Given this list of marker genes DNAJC16, RNF139, TSC1, UGT2B4, PROS1, EPB41L5, ACSF2, SYNCRIP, ASH2L, VCPKMT (valosin containing protein lysine methyltransferase), PRLR, NANOS2, RAB28, VCF1, NOD1, ZNF780B, CREBRF, THSD7B, AVL9, SLC17A7 (NCBI Gene Id 57030), LAMP3, CDC73, FAM229B, CCP110, AP3S1, EPHA4, MYCBP, MLF1, C2orf88, SLC35F5, NKAIN2, FAM118A, ATG16L1, LUC7L3, CDIN1, SYNC, BDNF, ATRN, MRPL3 (NCBI Gene Id 11222), RDH10, FOXJ3, ZNF736, PPP1R14C, ADAMTS15, UNC5D (unc-5 netrin receptor D), PIK3C2B, KIF5C, VPS13C, COX16, RAP2C, SYNJ2BP-COX16, ZXDB, B3GNT5 (UDP-GlcNAc:betaGal beta-1,3-N-acetylglucosaminyltransferase 5), SNX18, FOXN1, SMURF2, SPEN, STRN3, SLC22A4, SCAF8, CLMP, TRIP12, ZNF75D (zinc finger protein 75D), LRRC8C, SLC38A4, TLR4, BCO2, BRWD3, POLR3F, RCBTB2, VAMP4, SAMD9L, SACM1L, here is a description of the gene set: studied in species Homo sapiens Genes predicted to be targets of miRBase v22 microRNA hsa-miR-10397-5p in miRDB v6.0 with MirTarget v4 prediction scores > 80 (high confidence targets). Human Gene Set: MIR10397_5P from publication Chen Y, Wang X (PMID 31504780)